Given this list of marker genes MMP3 (NCBI Gene Id 4314), AGER (advanced glycosylation end-product specific receptor), TRPV1, PRKCA, SORD, SCN10A, MMP13, PRKCQ, TRPA1, TKTL1, MMP8, SLC2A3, PRKCG, MMP17 (NCBI Gene Id 51403), SNAP25, C3, MMP25, MMP12, MMP10, MMP27, MMP19, MMP2, PRKCB, MMP7, PRKCD, MMP15, MMP24, SCN9A, MMP16, PRKCH, SLC2A1, MMP21, PRKCE, MMP28, MMP9, MMP1, MMP23B, NOS2, PRKCZ, BDNF, PRKCI, MMP20, PRKD3, MMP11, SCN8A, MMP14, here is a description of the gene set: species: Homo sapiens Human Gene Set: WP_CHRONIC_HYPERGLYCEMIA_IMPAIRMENT_OF_NEURON_FUNCTION Chronic hyperglycemia impairment of neuron function